The following is a description of a gene set: Mouse Gene Set: GAZIN_EPIGENETIC_SILENCING_BY_KRAS The conversion of a normal cell to a cancer cell occurs in several steps and typically involves the activation of oncogenes and the inactivation of tumour suppressor and pro-apoptotic genes. In many instances, inactivation of genes critical for cancer development occurs by epigenetic silencing, often involving hypermethylation of CpG-rich promoter regions. It remains to be determined whether silencing occurs by random acquisition of epigenetic marks that confer a selective growth advantage or through a specific pathway initiated by an oncogene. Here we perform a genome-wide RNA interference (RNAi) screen in K-ras-transformed NIH 3T3 cells and identify genes required for Ras-mediated epigenetic silencing of the pro-apoptotic Fas gene. At least nine of these RESEs (Ras epigenetic silencing effectors), including the DNA methyltransferase DNMT1, are directly associated with specific regions of the Fas promoter in K-ras-transformed NIH 3T3 cells but not in untransformed NIH 3T3 cells. RNAi-mediated knockdown of any of the 28 RESEs results in failure to recruit DNMT1 to the Fas promoter, loss of Fas promoter hypermethylation, and derepression of Fas expression. Analysis of five other epigenetically repressed genes indicates that Ras directs the silencing of multiple unrelated genes through a largely common pathway. Last, we show that nine RESEs are required for anchorage-independent growth and tumorigenicity of K-ras-transformed NIH 3T3 cells; these nine genes have not previously been implicated in transformation by Ras. Our results show that Ras-mediated epigenetic silencing occurs through a specific, complex, pathway involving components that are required for maintenance of a fully transformed phenotype. Genes required for epigenetic silencing of FAS by activated KRAS in NIH 3T3 cells, based on RNAi screen. from publication Gazin C, Wajapeyee N, Gobeil S, Virbasius CM, Green MR (PMID 17960246) studied in species Mus musculus, and this is the list of marker genes: Bmi1, S100z, Sirt6, Pdpk1, Smyd1, Ctcf, Hdac9, Dot1l, E2f1, Eed, Npm2, Ezh2 (enhancer of zeste 2 polycomb repressive complex 2 subunit), Eid1, Mapk1, Trim66, Trim37, Mrgbp, Zfp354b, Dnmt1, Baz2a, Ptk2b, Asf1a, Rcor2 (REST corepressor 2), Map3k9, Zcchc4